Given this list of marker genes SUPT16H, CBX6, HDAC3, NRF1, HINT1, HES1, AMPD2, SORCS3, CNTN6, MEIS2, MAPRE1, RELL2, EGR1, CREBRF, ATOH1, here is a description of the gene set: species: Homo sapiens Human Gene Set: AHRARNT_02 Genes having at least one occurrence of the motif GRGKATYGCGTGMCWNSCC in the regions spanning 4 kb centered on their transcription starting sites. This matches the AHR transcription factor binding site V$AHRARNT_02 (v7.4 TRANSFAC).